The following is a description of a gene set: Human Gene Set: HP_OSTEOPOROSIS Osteoporosis Osteoporosis is a systemic skeletal disease characterized by low bone density and microarchitectural deterioration of bone tissue with a consequent increase in bone fragility. According to the WHO criteria, osteoporosis is defined as a BMD that lies 2.5 standard deviations or more below the average value for young healthy adults (a T-score below -2.5 SD). species: Homo sapiens, and this is the list of marker genes: CTBP1, CEACAM6, SLC7A7, POF1B, WNT3A, CALCR, POLG2, FGFR1, PWRN1, G6PC1 (NCBI Gene Id 2538), HLA-DQA1, DKK1, CYB5A, PIGT, MTRR, GORAB, DHX37, SLC11A1, FOXA2, PHKB, SPIB, PCCB, MIF, OCA2, MST1, HESX1, PRDM5, NPM1, TNFSF15, IGF1, LIMK1, DPAGT1, TGFB1, SRSF2, HTRA1, POU1F1, EDNRA, PPIB, CAVIN1, PDLIM4, MMEL1, SLC9A3, GATA4, BMP1, BMP15, GNPTAB, GALT, MAGEL2, SEMA4D, SLC25A19, SLCO2A1, GCM2, CDC73, HFE, CTC1, ASXL1, SLC25A4, NGLY1, GBA1, KISS1, RNU7-1, CTDP1, DUSP6, PRLR, CTCF, ELN, KDM1A, SRY, COL1A2, WRN, KCNN4, SNORD116-1, PROP1, KISS1R, FLRT3, SMAD3, BAZ1B, HLA-DQB1 (NCBI Gene Id 7924), IFT43, WDR35, ATRX, IL17RD, USB1, PROKR2, NOP10, MSH4 (NCBI Gene Id 4438), TBL2 (NCBI Gene Id 27203), UROS, NF1, MMP2, PRKAR1A (protein kinase cAMP-dependent type I regulatory subunit alpha), ANAPC1, NFIX, FKBP10, FKBP6, FAT4, BNC1, TCF12, KIT, COL1A1, PSTPIP1, ATP7B, DKC1, TENT5A, IL12RB1, NDN, RNU4ATAC, RRM2B, ANTXR2, SATB2, USP48, CFTR, COL7A1, FGF17, WDR11, HAMP, XYLT2, LAMA3, CYP17A1, NCF1, RECQL4, PMM2, HBB, AIP, TET2, SPARC, MRPS22, NSMF, HSD3B7, DNAJC30, CBL, RAB3GAP1, HMOX1, LIFR, CHD7, BMP2, PYGL (glycogen phosphorylase L), LETM1, PHKA2, CHST3, WDR19, CYP19A1, GPAA1, MALT1, ESR1, WT1, GTF2IRD1, EIF4H, ASAH1, GATA1, NHLH2, ZBTB20, WNT1, GK (NCBI Gene Id 2710), PRKACA, STAT6 (NCBI Gene Id 6778), TERC, SPIDR, MEN1, NR5A1, LHX4, POLD1, NDUFAF1, TRPV4, NHP2, NELFA, SPRTN, GNAS, VPS37D, ASXL2, ARMC5, STAT3, TMEM270, PDGFRB, PSMC3IP, PHKG2, RTEL1, BUD23 (BUD23 rRNA methyltransferase and ribosome maturation factor), FGF8, NR3C1, RUNX1, ATP7A, SH3PXD2B, WWOX, CPLX1, ADAMTSL2, SNORD115-1, HSD17B4, IFT122, ADCY10, BANF1, ALB (NCBI Gene Id 29004), MKRN3, PWAR1, GNRH1 (NCBI Gene Id 2796), PLOD2, RUNX2, METTL27, PLOD1, SOX3 (SRY-box transcription factor 3), ATP6V0A1, ZNF469, DCTN4, TRAPPC2, CLIP2, TNFRSF11A, SLC26A9, ZSWIM7, TMEM165, TGFBR2, SERPINA1, GPR35, CYP11A1, STX1A, CBS, HPGD, TMEM67, SIM1, GLI2, PDE11A, ESR2, RFC2, VPS53, SCARB2, SC5D, NOTCH2, GNRHR, MAP3K1, SLC34A1, SRC, LAMC2, SNRPN, CDH23, UROD, OTX2, NPAP1, TBCK, WRAP53, MMP1, GTF2I, NSD2 (nuclear receptor binding SET domain protein 2), MMP14, BRAF, PIGG, PRG4, ADAMTS2, LMX1B, CLCA4, LAMB3, STAT1, POU2AF1, RIN2, TNPO3, SOX9, PYCR1 (pyrroline-5-carboxylate reductase 1), KCNJ8, RPL10, GCLC, COL2A1, TCF4, HS6ST1, POLR3H, PCCA (NCBI Gene Id 5095), HERC2, HSPG2, SCN4A, ZFPM2, PROK2, GSTM3, TACR3, TRMT10A (NCBI Gene Id 93587), B3GALT6, MED12, IL12A, LMNA, LRP6, SMPD1, IFT52, CEACAM3, MLXIPL, TRIP11, NR0B1, CANT1 (NCBI Gene Id 619513), TMEM38B, NUP107, NHERF1, IFIH1, CCN6, SMS, SLC9A6, TNFRSF11B, TERT, B3GAT3, EIF2AK3 (eukaryotic translation initiation factor 2 alpha kinase 3), FSHR, ABCC9, PARN, SP7, SLC37A4, SGMS2, RPL11, PEX12, HJV, RNU4-2, BMP6 (NCBI Gene Id 7964), LRP5, TP53, SLC6A14, ERCC6, KDELR2, GLB1, USP8, GTF2IRD2, SPRY4, LARS2, POLG (NCBI Gene Id 5428), CYP27A1, TINF2, TYMS, WNK3, VAMP7, IRF5, TAC3, GALNS, TWNK